Given this list of marker genes Trpv4, Epb41l2, Fmnl1, Akap11, Rac2, Iqgap2, Epb41, Vil1, Ezr, Tnf, Synpo, Coro1c, Rab13, Strip1, Ppp2r3c, Kif21a, Tln1, Pls1, Racgap1, Nckap1, Plec, Fhod1, Actn1, Fmnl2, Ppfibp1, Pdcd6ip, Nlgn1, Ehd2, Kcnc3, Dlg1, Wdr1, Rock2, Iqgap3, Arf6, Rhobtb2, Rock1, Calr, Rtkn, Nckap1l, Anln, Rac1, Iqgap1, Epb41l1, Pafah1b1, Ikbkb, Rac3, Epb41l3, Llgl1, Ect2, Rhoq, Llgl2, Fmnl3, Cdk5, Septin7 (NCBI Gene Id 235072), Rhog, Fhod3, Ptk2b, Cavin3, Plek, Rhobtb1, here is a description of the gene set: Mouse Gene Set: GOBP_CORTICAL_CYTOSKELETON_ORGANIZATION studied in species Mus musculus A process that is carried out at the cellular level which results in the assembly, arrangement of constituent parts, or disassembly of cytoskeletal structures in the cell cortex, i.e. just beneath the plasma membrane.